The following is a description of a gene set: studied in species Mus musculus Mouse Gene Set: GOBP_T_HELPER_1_CELL_DIFFERENTIATION The process in which a relatively unspecialized T cell acquires the specialized features of a T-helper 1 (Th1) cell. A Th1 cell is a CD4-positive, alpha-beta T cell that has the phenotype T-bet-positive and produces interferon-gamma., and this is the list of marker genes: Ccr2, Anxa1, Tnfsf4, Irf1, Ascl2, Tmem98, Gadd45g, Nfkbiz, Relb, Mtor, Socs5, Hlx, Stat6, Il4, Lef1, Il4ra (interleukin 4 receptor, alpha), Sema4a, Ripk2, Ccl19, Ccr7, Hmgb1, Jak3, Stat4, Il18r1, Tbx21, Cracr2a, Il27, Spn